The following is a description of a gene set: Mouse Gene Set: REACTOME_DEGRADATION_OF_DVL studied in species Mus musculus Degradation of DVL, and this is the list of marker genes: Cul3 (NCBI Gene Id 98674), Psma1, Psmb7, Psma6, Psmb3, Psmd13 (NCBI Gene Id 23997), Psmb6, Psma5, Rps27a, Dact1 (dishevelled-binding antagonist of beta-catenin 1), Psmc4, Psmb5 (proteasome (prosome, macropain) subunit, beta type 5), Psmd7, Ubb, Rbx1, Psmd8, Psmd14, Psma3, Psma7, Psmd12, Hecw1, Psmc5, Klhl12 (NCBI Gene Id 240756), Psma4, Ubc, Psmc6, Dvl2, Psmd6, Dvl1, Psmb4, Psma2, Psmc1, Psmb2 (proteasome (prosome, macropain) subunit, beta type 2), Psmd1 (proteasome (prosome, macropain) 26S subunit, non-ATPase, 1), Psmb1, Adrm1, Uba52rt (ubiquitin A-52 residue ribosomal protein fusion product 1, retrotransposed), Psmc2, Psmd2, Dvl3, Psmd3, Psmd11, Uba52, Psmc3